Given this list of marker genes RCN2, PLEKHH1, MMP16 (matrix metallopeptidase 16), SRGAP3, MINDY2, WDR26, FOXO3, RUBCNL, KPNA3 (NCBI Gene Id 3839), SLC23A2, ATP2B1, SOX11, SP3, SCN3A, SLC26A7, OLFM1, IFNLR1, CDK17, QKI, KIF4A, SCAF8, ANKRD17 (NCBI Gene Id 84177), CDK2AP1, ZCCHC14, IGF1R, RASSF4, STMN1, WBP1L, RHOB (ras homolog family member B), SPRED1, PKNOX1, INPP5B, RNF4 (ring finger protein 4), CSNK1G1, MEF2C (myocyte enhancer factor 2C), CNEP1R1, UBTF, PDE4D, RPS6KB1, RBPJ, VNN1, ATP7A, ZBTB10 (zinc finger and BTB domain containing 10, NCBI Gene Id 65986), RAP2A, CALML4, SMARCD1 (SWI/SNF related, matrix associated, actin dependent regulator of chromatin, subfamily d, member 1), NLRP3, TMEM64, PDS5B, ACVR2A, NFIA, SLC8A1 (NCBI Gene Id 6546), HERC4, PTBP2, PHF20L1, LELP1, PRDM1, ANKRD16, SLC39A1, FBXW7, HHEX, ALCAM, MTPN (NCBI Gene Id 94351), EPB41L3, RALGPS2 (NCBI Gene Id 55103), FIGNL2, F3, NAA50, LMO2, STK39, SACS, SGMS2, STIM1, EFNA1, DERL1, CCDC140, ATP1B1, PLAGL2, SEPTIN6, FBXO8, TSPAN7, GARRE1, RASA1, CBFB, UBE2A, SLC35F1, SON, RAB8B (RAB8B, member RAS oncogene family), DUSP10, NFIB, RNF34, IL6ST, PDPK1, HSP90B1, CRIM1, PURB, MAP1B, WDR62, here is a description of the gene set: Genes having at least one occurence of the motif AACTGAC in their 3' untranslated region. The motif represents putative target (that is, seed match) of human mature miRNA hsa-miR-223 (v7.1 miRBase). species: Homo sapiens Human Gene Set: AACTGAC_MIR223